The following is a description of a gene set: species: Mus musculus Human Gene Set: PIONTEK_PKD1_TARGETS_DN Genes down-regulated during later stages of renal maturation (days P14-P16) in kidney specific knockout of PKD1. Autosomal dominant polycystic kidney disease is an important cause of end-stage renal disease, for which there is no proven therapy. Mutations in PKD1 (the gene encoding polycystin-1) are the principal cause of this disease. The disease begins in utero and is slowly progressive, but it is not known whether cystogenesis is an ongoing process during adult life. We now show that inactivation of Pkd1 in mice before postnatal day 13 results in severely cystic kidneys within 3 weeks, whereas inactivation at day 14 and later results in cysts only after 5 months. We found that cellular proliferation was not appreciably higher in cystic specimens than in age-matched controls, but the abrupt change in response to Pkd1 inactivation corresponded to a previously unrecognized brake point during renal growth and significant changes in gene expression. These findings suggest that the effects of Pkd1 inactivation are defined by a developmental switch that signals the end of the terminal renal maturation process. Our studies show that Pkd1 regulates tubular morphology in both developing and adult kidney, but the pathologic consequences of inactivation are defined by the organ's developmental status. These results have important implications for clinical understanding of the disease and therapeutic approaches. from publication Piontek K, Menezes LF, Garcia-Gonzalez MA, Huso DL, Germino GG (PMID 17965720), and this is the list of marker genes: SCARF2, RRM1, NDP, SERPINA1, OBSL1, AFP, TUBB, RPS6, DEFB119, CLDN11, ATP12A, CCNA2, H2AC8, H2AC7, PDGFA (NCBI Gene Id 5154), TUBA1A, HNRNPDL, UHRF1 (ubiquitin like with PHD and ring finger domains 1)